Given this list of marker genes FOXN3, ELAVL3, LINS1, STARD13, SP140L, MEX3B, ERF, TAF15 (TATA-box binding protein associated factor 15), COA3, HYCC2 (hyccin PI4KA lipid kinase complex subunit 2), XPO1, OLIG2, MIEF2, DNAJC4, INTS7, TUG1, WNT8B (Wnt family member 8B), NIPBL, HBA2, DBI, SDS, THG1L, SP2, ODAD3, LPCAT3, MYOCD, LRP2BP, PRKCSH, SYCP3, HNRNPR, CYP24A1, MAP3K13, HES1, SESN2, SLC9C2, NRL, CDH6, WASF2, SHC3, SF1, TLE1, LETM2, CNOT3 (NCBI Gene Id 9756), NID2, ORC4, SIX1, GATM, USP1, GPC3, SP1, ABCA7, FDPS, OTX2, GNB2, SNX20, DGKZ (diacylglycerol kinase zeta), ESRRB, TDO2, SELENOK, MROH7, DNAJC12, PTCHD4, SPATA20, ZFP91, OLFML3 (NCBI Gene Id 56944), FIZ1, PRCP, VPS29, SLC17A6, BRWD1, NRGN, CDH10, KCNT2, PRKCZ, TNFSF11, MEIS1, ADCY10, SEPTIN4, ASB7, UTP18, RHOQ, BRINP3, LDB2, SANBR, CD68 (CD68 molecule), ILF2, ZMYM2, MACROD2, RBM4, TPCN2, BAHD1, UBXN11, SKA2, ELK1, NT5DC2, ZNF524, ETAA1, KLHL4, PNRC2 (proline rich nuclear receptor coactivator 2), GART, TGFB3, DDIAS, POU3F3 (POU class 3 homeobox 3), ZEB2, HOXD10, PPP1R10, GLB1L2, SOST, MRE11, ZNF385A, PANK1, COL1A1, NEK2, USP5, HOXA10, SLC25A13, ASPM, AMELY, NDUFB3, FGF20, DLGAP5, UVRAG, TSC22D3, AGFG2, SFRP1, SLC26A9, CNTD1, POLA1, LMO3, ABCD2, CDCA3, MRPS18B, TMEM160, FLII, ZBTB10, DNAJB11, ABAT, DLG3, ACACA, ADNP2, SERTAD1, ELP6, UBE2C, USP21, RBM3, ZNF362, CDV3, PPP1R1B, CLRN1, DND1, SOX14, PTMA, MORN4, ATOH1, BRD2, ENAM, ZDHHC5, CKS2 (CDC28 protein kinase regulatory subunit 2), H2BC1, CCNG2 (NCBI Gene Id 901), CLTA, MAZ, SLIT3, ATF6B, CADM1, SSBP3, PDZD7, GGNBP2, UBB (ubiquitin B), SMAD6, PCP4, DLEU1, LRP8, FGF7, HK2, TOM1, OARD1, GRHL3, SPRY2, CIART, FAM117A, ATP2A2, WNT3, MID1, CDH1, SMAD2, CALM2, SLC25A4, DLEU2 (NCBI Gene Id 8847), PNRC1, NKX6-2, SLC25A35, SON, DUSP6, FLRT3, DHCR24, PRDM10, NFATC4, LRCH4, DLX3, PCF11, TMCC1, PPP2R2B, ISL1, AFAP1, PPM1B, ANKRD49, RAD51B, VCP, RGN, HOXA2, ARID4A, DDC (dopa decarboxylase), PAX1, LARP1, JARID2, CRYL1, ENSG00000228919, HNRNPL (NCBI Gene Id 91538), H2AC1, CDH9, RAB39A, KLF1, SLC25A25, RP2, SORBS2, ADAMTSL1, SORT1, HBA1, ZNF644, CNTN2, ERO1B, ELAVL4, RGS8, SNCA, HSCB, PCNA, C12orf57, AFF3, CALD1, ACTL6A, RAD9B (RAD9 checkpoint clamp component B), HSD17B12, UGP2, SLC25A10, ERG28, EBF2, ZSCAN2, STAMBP, FBXO24, ICAM5, EHF, DDX4, H3-3B, PRR11, ICAM4, FAR1, NFYA, TP63, ZMYM5, IRS1, DCAF11, GRIA3, here is a description of the gene set: species: Homo sapiens Human Gene Set: ALPHACP1_01 Genes having at least one occurrence of the motif CAGCCAATGAG in the regions spanning 4 kb centered on their transcription starting sites. This matches the PCBP1 transcription factor binding site V$ALPHACP1_01 (v7.4 TRANSFAC).